The following is a description of a gene set: Genes predicted to be targets of miRBase v22 microRNA hsa-miR-342-5p in miRDB v6.0 with MirTarget v4 prediction scores > 80 (high confidence targets). species: Homo sapiens from publication Chen Y, Wang X (PMID 31504780) Human Gene Set: MIR342_5P, and this is the list of marker genes: ACSL4, ARRB1, PFN1, FAF2, GALK2, ACLY, PPARGC1A (PPARG coactivator 1 alpha), SOX12, SFTPA2, PANO1, LIMD2, VSX2, SLC48A1, SHISA9, VPS52, CKB, TBC1D16 (TBC1 domain family member 16), EFHD2, ZNF774, FRZB, PPP1R1C, SAP30L, MYOZ3 (myozenin 3), GCM1, SPRED3 (sprouty related EVH1 domain containing 3), GPRC5A, SIGLEC14, SUMO1, HNRNPA1 (NCBI Gene Id 780920), BCL7B, WBP1L, ADAM8, SMR3B, ARHGEF18, VAC14, SYNGAP1, FOXI1, ZFP3, EFNA2, TDRD10, SETD9, TNFRSF6B, CASP9, CLDN7, FCER2, RHOH, TMEM150A, ITPKB, POFUT1, LINC03040, CCER2, ZBTB7A (zinc finger and BTB domain containing 7A), PTPRN2, CCAR2, CPLX2 (NCBI Gene Id 84242), SLC2A14, KCNC4, ITGB4, IGF2, MRTFB, UBE3B, MPL